Given this list of marker genes Csnk2a1, Ahr, Gas2, Mfn2, Bmal2, Nfya, Mtnr1b, 2510009E07Rik, Tef, Ppp1cb (protein phosphatase 1 catalytic subunit beta), Enpp2 (NCBI Gene Id 223584), Map2k6, Id3, Ptprn, Mtor (mechanistic target of rapamycin kinase), Prokr2 (NCBI Gene Id 246313), Bloc1s6, Rorc, Kdm8, Esr1, Pparg, Prkg2, Btbd9, Myh9, Casp2, Cckbr, 2610005L07Rik, F7, Rack1, Hs3st2, Zfp830, Gpr149, Nos3, Il6, Hnf1b, Cort, Ddx5, Opn4, Grin3a, Plekha1, Scn10a, Rorb, Mstn, Prf1, Grin1, Pde6b, Casp1, Csnk1d, Lgr4, Arrb1 (arrestin, beta 1), Sik1, Slit3, Grin2a, Sgpl1, Per3, Mybbp1a, Prok1, Pasd1, Nlgn1, Zfhx3, Spsb4, Pcna, Egfr, Prox1, Top1, Drd1, Kdm5c (NCBI Gene Id 399585, lysine demethylase 5C), Ptgds, Dtl, Ube3a, Ezh2, Tnf, Ptger3, Clock, Adora1, Axl (NCBI Gene Id 26362), Grk2, Mup2, Maged1, Mettl3, Lepr, Prkg1, Gabrb3, Mup11, Nms, Prokr1, Nos2, Prkaa2, Gpr176, Esr2, Lep, Usp2, Mup4, Nmu, Ass1, Dbp, Noct, Ahcy, Ncoa1, Foxo3, Ppp1ccb, Csf2, Ptger4, Pten, Notch1, Rock2, Pgr, Pml, Gpr157, Edn2, Zp3, Hdac2, Atf4, Schip1, Mat2a, Has2, Npr2, Nfkb2, Sohlh2, Ddb1, Chrna7, Fbxl21, Gsk3b, Agrn, Dpyd, Gdf9, Magel2, Hcrtr2, Ereg, Fbxl3, Siah2, Uts2r, Ghrh, Egr1, Dhx9, Rpe65, Kat2b (K(lysine) acetyltransferase 2B), Impdh2-ps, Src, Ces1d (carboxylesterase 1D), Sp1, Has1, Oas1d, Slc6a4, Creb1, Ppp1ca, Igf1r, Retn, Btrc, Stat5b, Trp53, Sirt1, Mapk10, Drd2, Sfpq, Tyro3, Adamts1, Nps, Cbx3, Gfpt1, Cartpt, Adrb1, Mttp, Cldn4, Twist1, Cyp1b1, Piwil2, Nr5a1 (NCBI Gene Id 26423), Casp3, Csnk1e, Ogt, Kiss1, Ppargc1a, Kat5, Fxr1, Atp1a3, Becn1, Hspa8, Htr7, Six3, Hnrnpu, Gdf10, Rai1, Mmp2, Ada, Pmch, Crem, Tnfaip6, Per1, Uts2, Pax4, Agrp, Hnrnpd, Phlpp1, Adrm1, Impdh2, Cntnap2, Dyrk1a, Kcna2, Atf5, Nfil3, Runx1 (NCBI Gene Id 12394), Oprl1, Igf1, Prkcg, Ppara, Rora, Enox2, Npas2, Chrnb2, Sirt6, Npy5r, Nlgn3, Id2 (inhibitor of DNA binding 2), Rbm4, Kcnma1, Crtc1, Usp7 (ubiquitin specific peptidase 7), Enox1, Suv39h2, Cry1, Sox14, Fshr (NCBI Gene Id 14309), Atg7, Hrh1, Ptn, Sin3a, Tardbp (NCBI Gene Id 97174), Crebbp, Cdk5, Rogdi, Lhcgr, Arrb2, Drd3, Th, Mta1 (metastasis associated 1), Drd4, Naglu, Nono, Nr2f6, Nppc, Thrap3, Nampt, Aanat, Hdac1, Suv39h1, Fas, Fbxw7, Alb, Nkx2-1, Nr0b2, Ncoa2, Ptx3, Nfilz, Ghrl, Hes7, Amh, Scaper, Opn5, Mapk8, Cipc, Prkaa1, Bdnf, Ankfn1, Nhlh2, Ncor1, Inhba, Klf9, Relb, Npy2r, Mtnr1a, Gabrb1, Huwe1, Fzd4, Ngf, Pla2g4a, Ahcyl, Mc3r, Tyms, Srebf1, Bmpr1b, Top2a, Prok2, Grin2b, Rbm4b, Kdm5b (lysine demethylase 5B), Atoh7, Mycbp2, Kdm2a (NCBI Gene Id 71431), Ccar2, Kcnh7, Col6a1, Cul4a, Homer1, Ppp1cc, Pde4d, Mdk, Nr5a2, Tnfrsf11a (NCBI Gene Id 21934), Fbxw11, Adnp, Parp1, Bmal1 (basic helix-loop-helix ARNT like 1), Klf10, Nr1d1, Cdk5r1, Nudt12, Adcy1, U2af1l4, Pln, Mup3, Ntrk2, Stat5a, Scn9a, Cdk1, Mup1, Prmt5, Hdac3, Mup5, Kmt2a, Scn11a, Abcb1a, Ntrk1, Nrip1, Cyp7b1, Mapk9, Per2, Ntrk3, Srrd, Pspc1, Oxtr, Id4, Zpbp2, Cry2, Hnf4a, Erbb2, Hlf, Agt, Kcnd2, Timeless, Ghrhr, Nr1d2, Bhlhe41, Ngfr, Tph1, Adora2a, Id1, Fshb, Adipoq, Ndufa9, A2m, Prkdc, Star, Kdm5a, Ep300, Mmp19, Setx, Usp9x, Ciart, Serpinf1, Bhlhe40, Cavin3, Slc26a6, Dnm1l, Afp, Pdgfra, here is a description of the gene set: Mouse Gene Set: GOBP_RHYTHMIC_PROCESS Any process pertinent to the generation and maintenance of rhythms in the physiology of an organism. studied in species Mus musculus